The following is a description of a gene set: Reactome Pathway: HCN channels electronically inferred by orthology from the curated human pathway species: Mus musculus part of: Potassium Channels This event has been computationally inferred from an event that has been demonstrated in another species.<p>The inference is based on the homology mapping from PANTHER. Briefly, reactions for which all involved PhysicalEntities (in input, output and catalyst) have a mapped orthologue/paralogue (for complexes at least 75% of components must have a mapping) are inferred to the other species., and this is the list of marker genes: Hcn4, Hcn3, Hcn2